The following is a description of a gene set: BACKGROUND: In patients with acute myeloid leukemia (AML) a combination of methods must be used to classify the disease, make therapeutic decisions, and determine the prognosis. However, this combined approach provides correct therapeutic and prognostic information in only 50 percent of cases. METHODS: We determined the gene-expression profiles in samples of peripheral blood or bone marrow from 285 patients with AML using Affymetrix U133A GeneChips containing approximately 13,000 unique genes or expression-signature tags. Data analyses were carried out with Omniviz, significance analysis of microarrays, and prediction analysis of microarrays software. Statistical analyses were performed to determine the prognostic significance of cases of AML with specific molecular signatures. RESULTS: Unsupervised cluster analyses identified 16 groups of patients with AML on the basis of molecular signatures. We identified the genes that defined these clusters and determined the minimal numbers of genes needed to identify prognostically important clusters with a high degree of accuracy. The clustering was driven by the presence of chromosomal lesions (e.g., t(8;21), t(15;17), and inv(16)), particular genetic mutations (CEBPA), and abnormal oncogene expression (EVI1). We identified several novel clusters, some consisting of specimens with normal karyotypes. A unique cluster with a distinctive gene-expression signature included cases of AML with a poor treatment outcome. CONCLUSIONS: Gene-expression profiling allows a comprehensive classification of AML that includes previously identified genetically defined subgroups and a novel cluster with an adverse prognosis. species: Homo sapiens Human Gene Set: VALK_AML_CLUSTER_9 from publication Valk PJ, Verhaak RG, Beijen MA, Erpelinck CA, Barjesteh van Waalwijk van Doorn-Khosrovani S, Boer JM, Beverloo HB, Moorhouse MJ, van der Spek PJ, Löwenberg B, Delwel R (PMID 15084694) Top genes from cluster 9 of acute myeloid leukemia (AML) expression profile; 87% of the samples are FAB M4 or M5 subtype, all have inv(16) inversion producing the CBFB-MYH11 fusion; indicate good survival., and this is the list of marker genes: ST18, RPS6KA2, CLIP2, COLEC12, EMID1, CD1C, NDE1, CHI3L1, PTPRM, SPARC, VSIG4, NRP1, NT5E, CHST12, AK5, OTULINL, CD81, FAM171A1, PAPSS2, BAHCC1, CLIP3 (CAP-Gly domain containing linker protein 3), ICAM4, RUNX3, MTMR11, MYH11, TGFBI, MSLN, CBFB, MGLL, TPPP3, DHRS3, MN1, CD59, FCGR2B, CLEC10A